The following is a description of a gene set: Human Gene Set: GSE360_T_GONDII_VS_B_MALAYI_LOW_DOSE_MAC_UP species: Homo sapiens Monocyte-derived dendritic cells (DC) and macrophages (MΦ) generated in vitro from the same individual blood donors were exposed to five different pathogens, and gene expression profiles were assessed by microarray analysis. Responses to Mycobacterium tuberculosis and to phylogenetically distinct protozoan (Leishmania major, L. donovani, Toxoplasma gondii) and helminth (Brugia malayi) parasites were examined, each of which produces chronic infections in humans yet vary considerably in the nature of the immune responses they trigger. from publication Chaussabel D, Semnani RT, McDowell MA, Sacks D, Sher A, Nutman TB (PMID 12663451) Genes up-regulated in comparison of macrophages exposed to T. gondii versus macrophages exposed to 5 worms/well B. malayi., and this is the list of marker genes: ATP2A2, AHCYL1, SLC5A6, KDR, BAAT, BICDL1, ATAD2B, AKAP13, CCT4, RPL34, SMARCB1, ITGA1 (NCBI Gene Id 3672), BANF1, RPP38, CCL7, IL2, RGS16, IDUA, ZNF593, U2SURP, GADD45B, ORC4, KCNA3, CTNNB1, SNRPA, PRMT3, CNOT9, PTPN9, PCSK1, SDC2, ATP1B2, PLAU, ATXN3, BRWD1, SNRPD2, SRGN, REPS1, TNFRSF9, H6PD, MISP, THBS2, CLOCK (NCBI Gene Id 9575), PTN, GAL, PLK2, EHD1, IFIT1, CORO2B, SLC46A3, PKIA, GP1BB, FBN2, PMPCB, RPS6KA5, FOLR1, TOMM34, PPBPP2, MAN1A1, FKBP9, FOSL2, STEAP1, RHOBTB3, COX6B1, AURKB, HSPA8, ODC1, PCGF1, CYC1, SRP14, PFKM, GTF2E1, THRA, PRMT1, PMPCA, PDE10A, PC, ELF3, PCBP2, MYH6, CPM, HS2ST1, SLC25A1, CPT1A, ALDH1B1, MCM2, GLA, SIK1, UBTF, CHD4, NDUFB8, FAM13A, RBM12, MORF4L2, ESRRA, EGF, ALG3, IDH2, SRM, MTF1, MAGI2, SLBP, ATP5MC3, POLR3C, UNC93A, BMS1, GADD45G, DLG4, SUGP1, MACIR (NCBI Gene Id 90355), ARAF, SLA, PDXK, CTDNEP1, ALDOB, CTAG2, FCGR3A, SLC6A8, UBXN7, GBP2, PLRG1, NDUFB6, MBD3, ATP5ME, BMERB1, USPL1, EEF1B2, CHAF1B, FLT1, NCOA1, ZFP36L2, CCDC85B, SERPINH1, RAB33A, KCNB2, TSPAN31 (NCBI Gene Id 6302), VAMP2, RASSF1, PIK3R3, LPAR2, ADCY1, HMGCS2, MEN1, PGGT1B, CCP110, EML3, CHML, IMPDH2, LSM4, ZBTB25, PCM1, BRD3, NAA10, FLNB, CALCOCO1, ESPL1, SMAD1, FMNL1, GNA11, REL, ATIC, NELFE, ACADVL, MYCL, IGFBP5, TENT4A, MAGEB2, UBE2L3, CD163, SYK, LCP1, EHBP1, PFKFB1, SRRD, CALM3, GLIPR1, CDKN2C, MPHOSPH8, PLS3, PCDHB17P, RNGTT, BRAF, LIG3, WASF1, PURA, RWDD2A, XYLT1, ENG (endoglin), DNAJC13 (NCBI Gene Id 285196), CSRP3, ADAM8, SP3, ID3, DDT, RNF19B, MAP4K5, CACNG3